The following is a description of a gene set: studied in species Mus musculus The process in which the labyrinthine layer of the placenta is generated and organized. Mouse Gene Set: GOBP_LABYRINTHINE_LAYER_MORPHOGENESIS, and this is the list of marker genes: Grhl2, Bmp5, Lef1, Tmed2, Zfp36l1, Fzd5, Itga4, Gjb5, Socs3 (suppressor of cytokine signaling 3), Ncoa3, Fgfr2, Ncoa1, St14, Il10, Llgl2, Spint2, Adm, Ccn1, Spint1, Dnajb6, Vcam1, Esx1, Wnt7b, Grb2, Gcm1, Erf, Rspo3, Bmp7